The following is a description of a gene set: Human Gene Set: GOBP_VENTRICULAR_CARDIAC_MUSCLE_CELL_ACTION_POTENTIAL An action potential that occurs in a ventricular cardiac muscle cell. studied in species Homo sapiens, and this is the list of marker genes: SCN3B, KCNE3, NOS1AP, RNF207, CAV3, DSP, KCNE1, NEDD4L, KCNE4, CASQ2, KCNE2, KCNQ1, CACNA1C, BIN1, TRPM4 (NCBI Gene Id 8184), JUP, DSG2, NOS1, ANK2, KCNJ3, DLG1 (NCBI Gene Id 1739), DSC2, SNTA1, GPD1L, GJA5, MIR133A1, KCNH2, RYR2, KCNJ8, PKP2, KCND3, SCN2B, SCN5A, KCNJ5, CAV1, MIR1-1, KCNE5, CTNNA3